The following is a description of a gene set: Genes up-regulated in bone marrow-derived macrophages treated with LPS for 2h: heterozygous versus homozygous knockout of MLL4. studied in species Homo sapiens from publication Austenaa L, Barozzi I, Chronowska A, Termanini A, Ostuni R, Prosperini E, Stewart AF, Testa G, Natoli G (PMID 22483804) Histone methyltransferases catalyze site-specific deposition of methyl groups, enabling recruitment of transcriptional regulators. In mammals, trimethylation of lysine 4 in histone H3, a modification localized at the transcription start sites of active genes, is catalyzed by six enzymes (SET1a and SET1b, MLL1–MLL4) whose specific functions are largely unknown. By using a genomic approach, we found that in macrophages, MLL4 (also known as Wbp7) was required for the expression of Pigp, an essential component of the GPI-GlcNAc transferase, the enzyme catalyzing the first step of glycosylphosphatidylinositol (GPI) anchor synthesis. Impaired Pigp expression in Wbp7-/- macrophages abolished GPI anchor-dependent loading of proteins on the cell membrane. Consistently, loss of GPI-anchored CD14, the coreceptor for lipopolysaccharide (LPS) and other bacterial molecules, markedly attenuated LPS-triggered intracellular signals and gene expression changes. These data link a histone-modifying enzyme to a biosynthetic pathway and indicate a specialized biological role for Wbp7 in macrophage function and antimicrobial response. Human Gene Set: GSE30971_WBP7_HET_VS_KO_MACROPHAGE_2H_LPS_STIM_UP, and this is the list of marker genes: NAT1, C1orf54, CENPN, PINLYP, MRAS, FBP1, KITLG, LAPTM5, CLEC7A (NCBI Gene Id 64581), ACVR2A, SAMHD1, DBF4, ITGAM, ITFG1, GNA13, RAP1GDS1, PGD, PHPT1, ZFC3H1, BIN1, FOS, ENC1, LPXN, CARD19, CHST11, SLC37A2, CD36, ERRFI1, CEP20, STK38L, SC5D, LPCAT2, DOCK10, RAB7B, AGO1, GFOD1, SPIN4, TUSC2, NDUFB4, VMO1, DISP1, CD1E, A2M, DECR1, P3H2, FCN1, ADO, FILIP1L, RAPH1, HCLS1, ZMYND8, ENY2, CCL24, DHX32, LYPLAL1, DCSTAMP, ZNF281, KIAA0513, SRD5A3, RBPJ, RNASE6, ME1, H2BC21 (H2B clustered histone 21), TMEM170B, PFKFB4, IL18BP, PPT1, GTF2E1 (general transcription factor IIE subunit 1), RNF135, LSP1, MPP1, SLC49A4, RASAL2, LPAR1, UBASH3B, CHKA, RGS1, SPOCD1, RPS19BP1, TM6SF1, PKM, ETNK1, SNX30, IL1R2, SLC16A6, LRRK2, CLEC5A, EML4, KLHL26, PRCP, CD9, TRMT5, RGCC, CERK, MPLKIP, UQCR10, ITGB2, TNFSF14, NCF2, CD84, FGL2, FN1, HMGN2, SEMA4D, NCEH1, RASSF5, TXNDC12, PLXDC2, G6PD, IRGQ, DRAP1, OR52K3P, PLA2G15, CD226, CD101, CAMSAP2, TIMM8B, HAT1, LSM12, COX7B, GAPDH, TRPS1, ERGIC2, LGALS9, ABHD6, CCDC159, ALDH3A2, PAPSS1, SPP1, GABARAPL1, LIPA, PJA1, SQLE, MPV17, LST1, LINC00842, SLC25A40, SCG5, EVI2A, TXNRD1 (thioredoxin reductase 1), SLC22A4, SLC1A3, TGFB1, ARHGAP26, HOMER3, ACAA2, KLF9, MRC1, SLC9A9, VSIG4, CAMTA1, PON2 (NCBI Gene Id 5445), IL1RAP, ETHE1, SERPINE1, FAM200B, SCPEP1, FPR3, SPTLC3, MALT1, TXNIP, S1PR3, TMEM45B, CAMK1, HHEX, DENND1B, AVPI1, C3orf80, MMP9, HNRNPLL, TRIM24, MYG1, PADI4, LINC02035, RDH11, PTGFRN, SPRY2, CD1B, PLAU, DEFB1 (defensin beta 1), AURKA, FAM135A, HMG20B, NDUFA4, ABHD2, AKR1C3, TBC1D1, CASS4, C5AR2, GPAT3, SKAP2, GREM1, ITGB2-AS1, ARHGAP18, CD300LB, MITF, NDUFB2, ANKH, HPCAL1